The following is a description of a gene set: Genes down-regulated in CD8 T cells treated by inteferon alpha: wildtype versus STAT4 knockout. from publication Gil MP, Ploquin MJ, Watford WT, Lee SH, Kim K, Wang X, Kanno Y, O'Shea JJ, Biron CA (PMID 22968462) studied in species Homo sapiens Human Gene Set: GSE40666_WT_VS_STAT4_KO_CD8_TCELL_WITH_IFNA_STIM_90MIN_DN Type 1 IFNs can conditionally activate all of the signal transducers and activators of transcription molecules (STATs), including STAT4. The best-characterized signaling pathways use STAT1, however, and type 1 IFN inhibition of cell proliferation is STAT1 dependent. We report that type 1 IFNs can basally stimulate STAT1- and STAT4- dependent effects in CD8 T cells, but that CD8 T cells responding to infections of mice with lymphocytic choriomenigitis virus have elevated STAT4 and lower STAT1 expression with significant consequences for modifying the effects of type 1 IFN exposure. The phenotype was associated with preferential type 1 IFN activation of STAT4 as compared to STAT1. Stimulation through the TCR induced elevated STAT4 expression, and STAT4 was required for peak expansion of antigen-specific CD8 T cells, low STAT1 levels, and resistance to type 1 IFN-mediated inhibition of proliferation. Thus, a mechanism is discovered for regulating the consequences of type 1 IFN exposure in CD8 T cells, with STAT4 acting as a key molecule in driving optimal antigen-specific responses and overcoming STAT1-dependent inhibition of proliferation., and this is the list of marker genes: CD40, DGCR2, SOAT1, MCRIP2, DHX58, PLS1, RNF43, C1orf122, FAM174B, HGSNAT, CRMP1, CD160, BBS12, TLE4, CHEK1, PPA1, RGCC, CD38, LPXN, CARNMT1, ATF6, CCRL2, CD99, FOXRED2, IL18R1, UBE2V1, SEPTIN11, WFIKKN2, CRTAP, CTSW, PARP12, NKG7, PLAC8, BID, SALL2, FKBP2, ANKRD63 (ankyrin repeat domain 63), NT5M, TLR7, SCRN2, IFIT1B, PPP1R14B, MTHFD2L, RAB32, ARHGAP18, RPS19BP1, SRGN, KCTD12, IL17RB, SLC3A2, B4GALNT4, IL1R1, PEBP1, ZNF629, CFAP20DC, TMEM39B, SCAMP3, AK7, PXDC1, MAGED1, RUNX3, SH3BGRL2, NAGA, RAB4A, KLHL25, ASNS, PAK1, CKS1B, PFDN1, ALAD (NCBI Gene Id 210), LRPPRC, UBE2E2, EMID1, PEX5, TMEM64, FAR1, FAM3C, MYB, ADAM8, FOSL2, C11orf54, HACD3, EGR2, ORAI3, PON3, TRPM4, RABGGTB, ATP8B4, IKZF2, NCMAP, LGALS1, SMYD2 (SET and MYND domain containing 2), NEFH, VDAC1, PLK3, XCL1, IPO7, RRP1B, CEP41, EIF4EBP2, EIF2AK2, TGIF1, HIVEP3, CMTR1, SSBP3 (NCBI Gene Id 55126), PPIC, BOLA3, KLRD1, OAS1, UNC119, AHR, RAD51B, GNPTAB, MAFG, SLC17A5, IL4, RTN3, TLCD2, ACOT11, ENG, SCARB1, VAMP5, PTPRF, CX3CR1, CTSA, OAS2, MCM8, WEE1, MCM5, DTNBP1, FARP1, PFAS, SMIM3, APLP1, MRPS6, SCPEP1, XBP1, RAP1A (NCBI Gene Id 5906), RNF145, TCP1, PSEN1, FABP5, F2R, LCLAT1, TRAFD1, CST7, FES, ENDOD1, TDRD7, PHGDH, OSBPL5, RANBP1, RNF144A, NEK6, PGAM1, MGLL, TJP2, SLC29A1, IL13, S100A10, CRELD2, SRSF9, SMCO4, SEMA4A, FAM162A, RASSF5, RNF149, FLOT1, ACYP2, ID2, SMARCB1 (NCBI Gene Id 6598), TRPV2, DCTD, PRKCH (protein kinase C eta), FGD5, RHOD, SLC39A6, SHMT2, TRIP13, DNAJC18, TMEM126A, LITAF, GTF2IRD1, SRM, IKZF3, TCEAL9, STK26, ZNF518B, FAM167A, CLSPN, PTPRJ, NTRK3, CDKN2A, FRRS1, MSRA, ABI2, YBX3, SLC43A2, COMTD1, TSPAN4